The following is a description of a gene set: This event has been computationally inferred from an event that has been demonstrated in another species.<p>The inference is based on the homology mapping from PANTHER. Briefly, reactions for which all involved PhysicalEntities (in input, output and catalyst) have a mapped orthologue/paralogue (for complexes at least 75% of components must have a mapping) are inferred to the other species. studied in species Mus musculus electronically inferred by orthology from the curated human pathway Reactome Pathway: Signaling by NTRK2 (TRKB) part of: Signaling by NTRKs, and this is the list of marker genes: Bdnf, Ntf5, Fyn, Grb2 (NCBI Gene Id 14784), Frs2